The following is a description of a gene set: Human Gene Set: GOBP_B_CELL_APOPTOTIC_PROCESS species: Homo sapiens Any apoptotic process in a B cell, a lymphocyte of B lineage with the phenotype CD19-positive and capable of B cell mediated immunity., and this is the list of marker genes: ORMDL3, BAK1, IL10, IRS2, TRAF3IP2, NFKBIZ, BCL6, MYC, BCL10, AURKB, IL2, MIF, FOXP1, TNFRSF21 (NCBI Gene Id 51323), FNIP1, PDCD1, CRKL, BTK, NOC2L, BCL2, CD74, LYN, PKN1 (NCBI Gene Id 5585), HSH2D, ADA, SLC39A10, BAX, MIR17HG